Given this list of marker genes EBF1, NLK, FUT7, AMOTL1, EIF4G1, CASKIN2, TUT1, ZDHHC24, PAN2, MIA (MIA SH3 domain containing), CACNG3, FLOT1, ASH1L, GDPD5 (glycerophosphodiester phosphodiesterase domain containing 5), CD86, DDR1, ASCL3 (NCBI Gene Id 56676), HIVEP1, AAMDC, MLLT11, ARHGEF2, RIN2, CREB1, NFKBIB, PRRT2, NFAT5, RPS6KA4, UBE2D3, PURG, DCLK1, CYP2D6, ICAM1 (intercellular adhesion molecule 1), SEC63, TJAP1, BMF, CD70, BAZ2B, BIRC3, HTR3B, IL27, HSP90B1, ENO3, ZMYND15, TP63, LAMA1, SIRT2, TSLP, IER3, PRDM12, ABI3, TSEN54, RND1, IER5, MAPK6 (mitogen-activated protein kinase 6), CLCN1, CDK6, ILK, TNFRSF1B, DAP3, PCDH10, LINC01138, NR2F2, STAT6, COQ8B, TCEA2, NFKBIA, TNFSF18 (TNF superfamily member 18), TRPC4, CCDC107, GADD45B, MMP9, LRCH1, PPP1R13B, CLOCK, CXCL11, SLC6A12, SOX10, JAK3, TNFRSF9, UBE2H, GATA4, NFKBID, CTDSPL2 (CTD small phosphatase like 2), MIR17HG, SUCO, YY1AP1, GPM6A, CXCL16, TRIB2, TSPEAR, TLX1, SH2B3, UPF2 (UPF2 regulator of nonsense mediated mRNA decay), SOX5, ALG6, MADCAM1, CD69, RFX5, SIX4, ZDHHC8, PCSK2, PARP8, KRT36 (keratin 36), CHD4, KRT23, S1PR2, NFKB2, SLC12A2, LTB (lymphotoxin beta), BDNF, IL17C, MIDEAS, YWHAQ, FTHL17, FAM117A, PTHLH, BCL6B (NCBI Gene Id 7613), WNT10B, STX4, SDC4, ZFHX3, TNIP1, WRN, HSD3B7, CHD6, CUEDC1, TATDN1, CYLD, CALCOCO1, WNT4, CLCN2, MAP3K11, ITPKC, FGF12, ACTN3, PNKD, CD40, RNF43, DOCK4, SLC16A6, UBE2I, EIF5A, RANBP10, SMPD3, WRAP53, TSNAXIP1, UACA, REL, RPS19, VEZF1, ATP1B1, MOB3C, FGF17, IL13, CXCL10, GNGT2, FAM43B, GRK5, PTGES, GNG4, MLLT6, ORAI1, RASSF2, CLDN5, FGF1, ERN1 (endoplasmic reticulum to nucleus signaling 1), SIN3A, E2F3, BCL3, RSF1, HNRNPR, YWHAZ, TFE3, MITF, LIX1L, APPL1, G3BP1, EHF, PFN1, CXCR5 (C-X-C motif chemokine receptor 5), COL11A2, CTDSP1, NXPH4, GPBP1, C1QL1, STX19, KAT7, IL1RAPL1, TP53, COL16A1, SIX5, MSX1, TLX3 (NCBI Gene Id 30012), DSC2, EIF4A2, TNFSF15, RASGRP4, UBD, RELB, RAP2C, SMOC1, ZIC4, CCM2L, TIAL1, KANSL1L, MAP3K8, RBMS1, PLXNB1, BLCAP, PCBP4, FOXS1, CDC42SE1, PCDH12, TBC1D17, GREM1, ACAN, RRAS, CSF1R, MAML2, TRAF4, KCNN2, MSC, RRP8, KCNT2, ZEB1, SOX3, KLK9, CSF2RB, TRIM47, BMP2K, SLAMF8, SP6, AKT1S1, KY, SLC44A1 (solute carrier family 44 member 1), NDUFB9, IL6ST, WNT10A, POU2F3, IFNB1, CCL5, here is a description of the gene set: studied in species Homo sapiens Human Gene Set: NFKAPPAB65_01 Genes having at least one occurrence of the motif GGGRATTTCC in the regions spanning 4 kb centered on their transcription starting sites. This matches the RELA transcription factor binding site V$NFKAPPAB65_01 (v7.4 TRANSFAC).